The following is a description of a gene set: Any process that increases the frequency, rate or extent of the regulated release of insulin that contributes to the response of a cell to glucose. studied in species Mus musculus Mouse Gene Set: GOBP_POSITIVE_REGULATION_OF_INSULIN_SECRETION_INVOLVED_IN_CELLULAR_RESPONSE_TO_GLUCOSE_STIMULUS, and this is the list of marker genes: Nadk, Cacna1d, Crh, Adcy8, Ghrl, C1qtnf12, Slc2a2, Trpa1, Lepr, Hif1a, Prkn, Cftr, Gprc6a, Sirt1, Sybu, Atg7, Bad, Tunar, Kif5b, Nr1h4, Fto, Baiap3, Hcfc1, Camk2n1, Abcc8, Gpr39, Rfx6, Myh9, Oxct1, Abcg1, Rac1, Gpld1, Ncoa6, Lrp1, Gcg, Trpm5, Stx4a, Pdx1, Mpc2, Agt, Ppp3cb, C2cd2l, Ppard (peroxisome proliferator activator receptor delta), Dynll1, Ano1, Mlxipl, Vsnl1, Gpr27, Gpr68, Arrb1, Trpm4, Osbp, Pla2g6